Given this list of marker genes AGR2, CD151, SSRP1, RAB1B, MRPL15, SCN4A, CCT7, LCN2, CAPN6, MAPK11, VTA1, FDFT1, PSMA2, EIF3D, EIF3G, COPS4, GABARAPL2, ANGPT2, MRPL46, HPRT1, LRRN4CL, TUFM (NCBI Gene Id 7284), MRPL38, LAMTOR3, NMT1, TIMP1, RABAC1, NOP16, HSPD1, PIGX, GTF2H2, QSOX2, SDF2L1, EFTUD2 (NCBI Gene Id 9343), CLDND1, SEC11A (SEC11 homolog A, signal peptidase complex subunit), AP1S1, MRPS33, HAGH, CNBP, CDC42EP5, DARS1 (NCBI Gene Id 1615), TPMT, NDUFB10, AGPAT3, SUMO2, NDRG2, QPCT, MRPL52, HACD2, MAPK8IP1 (mitogen-activated protein kinase 8 interacting protein 1), APOD, TOMM22, SNRPC, HSD17B10, IGFBP3, LRRC59, PDCD5, ACOT13, CDK2AP1, PRMT5, POLR1D, RBBP9, PGK1, PSMB10, SKP1, CDH18, NIPSNAP3B, TCP1, UXT, PPP6C, EIF4A1, HDGF, CASP6 (caspase 6), LLPH, NDUFA9, PIGP, HIBADH, PKIG (NCBI Gene Id 11142), ZBTB32, NUDT14, BAG1, LONRF1, SUMO3, ISG20, CHCHD4, PON3, EPYC, COMMD6, NIFK, RAB11B, RAB5C, MRPL39, ATP6V1E1, NAGPA, LSM3, PLS3, ALAS1, SNTG1, NCAPH2, GHITM, KARS1, TRMT112, PSMG4, TMCO1, PRDX2, ITM2C, MAP2K1, MSRB1, PSAT1, PPBP, CCT3, GABARAP, GLA (galactosidase alpha), GSTM3, PHGDH, RCAN1, RHBDD1, MFSD2A, ATP5MK, PGAP2, PRKAG1, SKIC8, OGFR, EXOSC1, GDI2, ME1, GAMT, IGF2BP3, RCN3, EIF2A, RSPH14, RWDD4, C18orf32, SRM, CIB1, COPS5, PPP1R11, SARNP, ABHD4, CD69, CRIPT, HAUS7, ACTR10, CTSL, EIF3F, GDE1, AIP, TSPO, HSP90AB1, TLCD3A, FUCA1, UBE2A, H4C6, ERGIC1, CALM2, DOC2B, MREG, DHCR7, RRAS, TMEM109, AK1, INO80C, NRG1, LMAN2, SERPINB9, ZDBF2, IL36G, here is a description of the gene set: from publication Dhodapkar KM, Banerjee D, Connolly J, Kukreja A, Matayeva E, Veri MC, Ravetch JV, Steinman RM, Dhodapkar MV (PMID 17502666) Genes up-regulated in monocytes: untreated versus anti- FcgRIIB. Human Gene Set: GSE7509_UNSTIM_VS_FCGRIIB_STIM_MONOCYTE_UP species: Homo sapiens The ability of dendritic cells (DCs) to activate immunity is linked to their maturation status. In prior studies we have shown that selective antibody-mediated blockade of inhibitory FcgRIIB receptor on human DCs in the presence of activating immunoglobulin (Ig) ligands leads to DC maturation and enhanced immunity to antibody-coated tumor cells. Here we show that Fcg receptor (FcgR) mediated activation of human monocytes and monocyte-derived DCs is associated with a distinct gene expression pattern, including several inflammation associated chemokines as well as type 1 interferon (IFN) response genes including the activation of signal transducer and activator of transcription 1 (STAT1).